The following is a description of a gene set: Human Gene Set: WP_HEPATITIS_C_AND_HEPATOCELLULAR_CARCINOMA species: Homo sapiens Hepatitis C and hepatocellular carcinoma, and this is the list of marker genes: MMP1, SMAD3, MIR34A, PTGS2, JUN, MIR24-1 (NCBI Gene Id 407012), MIR92A2, AKT1, LEF1, CDKN1A, PTPN11, VEGFA (vascular endothelial growth factor A), MYC, CXCR1, CTTN, MYOF, GRB2, TP53, COL4A2, CCND1, CXCL8, BIRC3, CASP3, TGFB1, UCHL1, HIF1A, CASP7, IL6, MIR24-2, MIR92A1, HNF1A, IL6R, MAPK3, RRM2, BIRC5, BRCA1, JAK1, CASP9, E2F2, MIR155, NFKB1, MAPK14, SOS1, PODXL, FRZB, FASLG, STAT3, CD44, RAC1, BCL2L1, MAPK8, TGFBR1, NOS2, VAV2, SMAD4, MIR744